Given this list of marker genes DVL1, SNCA, CLSTN3, LRFN5, NTNG2, GPC4, PTPRD, DAAM1, LRFN3 (NCBI Gene Id 79414), LRRTM3, TLN2 (talin 2), BSN, VPS35, PCDH17, DKK1, NLGN2, NRXN1, CACNA2D3, FZD1, SLITRK3, SNAPIN, C5AR1, CBLN1, IL1RAPL1, IL1RAPL2, CLASP2, SLITRK2, NLGN1, MDGA1, LRFN4, FARP1, WNT3A, APP, LRRC4B, CAP2, IGSF11, NLGN3, ARF6, LRP4 (LDL receptor related protein 4), NLGN4X, EIF4G1, GRID2, CHD4, EFNB2, PTEN, NTRK3, IL1RAP, PFN2, MIR431, CNTN5, WNT5A, PPFIA2, NLGN4Y, SLITRK1, PCLO, PLS3, WNT7A, here is a description of the gene set: A process that is carried out at the cellular level which results in the assembly, arrangement of constituent parts, or disassembly of a presynapse. Human Gene Set: GOBP_PRESYNAPSE_ORGANIZATION studied in species Homo sapiens